The following is a description of a gene set: Human Gene Set: GSE2405_0H_VS_3H_A_PHAGOCYTOPHILUM_STIM_NEUTROPHIL_DN Genes down-regulated in polymorphonuclear leukocytes (3h): control versus infection by A. phagocytophilum. Polymorphonuclear leukocytes (PMNs) were obtained from healthy individuals in accordance with protocols approved by the Institutional Review Board for Human Subjects at the University of Minnesota and the National Institute of Allergy and Infectious Diseases. PMNs (107) were combined on ice with live S. aureus (108) or with live or heat-killed A. phagocytophilum (bacteria isolated from 5x106 infected HL60 cells for a ratio of 1 infected HL60 cell: 2 PMNs, ~ 5-20 A. phagocytophilum: PMN) in wells of a 12-well tissue culture plate (pre-coated with 20% autologous normal human serum). Unstimulated control assays received either buffer (for S. aureus comparisons) or clarified HL60 lysate (for A. phagocytophilum comparisons). Plates were centrifuged at 350 x g for 8 min at 4oC to synchronize phagocytosis and incubated at 37 deg. C in a CO2 incubator for the indicated times. At the indicated times, tissue culture medium was aspirated from the plate and PMNs were lysed directly with RLT buffer (Qiagen, Valencia, CA). Purification of PMN RNA and subsequent preparation of labeled cRNA target was performed as described in Methods. Labeling of samples, hybridization of cRNA with HU133A oligonucleotide arrays (Affymetrix, Santa Clara, CA), and scanning were performed according to standard Affymetrix protocols ( http://www.affymetrix.com/pdf/expression_manual.pdf ). Experiments were performed in triplicate, using PMNs from three healthy individuals for each treatment. from publication Borjesson DL, Kobayashi SD, Whitney AR, Voyich JM, Argue CM, Deleo FR (PMID 15879137) studied in species Homo sapiens, and this is the list of marker genes: DES, DEFA6, DNAH14, CDH1, CNKSR3, CDHR2, ANKRD18A, BRD7P3, ANKRD30B, AMACR, EDA, CSTL1, FMN2, EGR2, CYP4A22, CELSR1, DMGDH, H1-8, FAM24A, APCDD1, ANGPT4, EYA1, GHR, DPT, CXCL11, CLEC4F, C4BPA (NCBI Gene Id 722), GGTLC1, GSTA5, LINC00649, ART4, CCER1, ABCC8, RHEX, ALS2CL (NCBI Gene Id 338373), GNG11, GLRA1, ASIC3, DNAJB8, AHSP, GPR148, B3GALT5-AS1, DSG3, DLGAP2, EVPL, LINC02868, DRC7, GFRA3, AGT, ANKRD42, CHRNB2, DIPK1C, ACAD10, ADAMTSL4, AFM, CD226 (CD226 molecule), APLNR, FER1L5 (NCBI Gene Id 90342), DOCK10, DHRS7B (NCBI Gene Id 82068), CD1D, ARL13A, COL4A2, C1S, BHMT, LINC00518, C1QTNF2, CLIC4, DDX6, GP1BA, DSG1, LLCFC1, METTL24, COLEC11, CRYBB2, ARRDC3, NYAP1, AKAP12, GALNT13, BATF2, UTP25, CD200R1, CDH12, ANKK1, ADGRG2, EPHA4, ASCL4, EFS, CEP250, APOL5, EME1, ADCY10, GLYAT (NCBI Gene Id 10249), CCNB2, ARL4A, CDC25A, DNAH9, HSPB7, GGTA1, ASTL, HDX, GABRR1, TBC1D22A-AS1, ACRV1, RPP38-DT, STKLD1, ADGRB3, FAM90A1, FSTL3, GASK1A, HNF1B, RIPOR2, ADAT1, BHMT2, ADAMTS16, EBF1, FOXI1, COBL, BARHL2, CASS4 (NCBI Gene Id 57091), CDKN2AIPNLP1, GJB3, ADGRG3, ATG16L1 (autophagy related 16 like 1), MCEMP1, LINC00898, CLEC2B, DSCR8, HCAR3, CIBAR2, CMA1, DGKK, BPIFA3, HCAR2, CSF3R, BMAL2, C22orf46P, HYAL2, CRIM1, C1QTNF1, HSD3B7, CDX2, CILP, FUT5, CNGA2, ELOVL3 (NCBI Gene Id 83401), CMTM2, AMOT, CST1, ENPP5, HSP90B1, FETUB, CAPN7, HAS2, DEPDC1B, ADH1B (alcohol dehydrogenase 1B (class I), beta polypeptide), FAM209B, CBFA2T3, COL13A1, COL8A2, CHML, ADAMTS17, EPGN, CHEK2, CNOT6L, CDO1, GRB7, FSHR, DNAJC9, CEP131, DAG1, CHD5, ASPRV1, CNR1, G6PC1, C1R, DDX39B, SPATA6L, CLSTN2, C6orf141, PLAAT1, ADGRV1, CYP4F3, ABCC2, HCG4, CXCL10, ENPP6, AMTN, CACNA2D1 (NCBI Gene Id 781), CYP1B1, CLXN, FSCB, IZUMO1R, TRABD2A, CYP4B1, CAMK4, ADA, DQX1